The following is a description of a gene set: Mouse Gene Set: MIR_342_3P studied in species Mus musculus from publication Chen Y, Wang X (PMID 31504780) Genes predicted to be targets of miRBase v22 microRNA mmu_miR_342_3p in miRDB v6.0 with MirTarget v4 prediction scores > 80 (high confidence targets)., and this is the list of marker genes: Cep97, Far1, Tctn1, Clec1b, Kdm6b, Knop1, Gucy2c, Zfy1, Nip7, Arhgef4, Akirin1, Ms4a4d, Slc39a13, Zbtb26, Rad51d, Rpgr, Ddo, Ostn, Susd1, Ddx3x, Hivep1, Wdr77, Trpc6, Jazf1, Adam28, Tro, Tfdp2, Vax2, Eif4e, Pramel29, Socs6, B3gnt6, Kdsr, Chst15, Cisd2 (NCBI Gene Id 99732), Prelp, Stk4, Plxna4, Itfg2, Fut8, Cacna1c, Selenot, Snap25, Klhl15, Armcx3, Plk2, Casp2, Mmab, Col1a2, Hycc2, Tcf12, Jade1, Nkap, Tulp3, Elavl2, Fgf10 (NCBI Gene Id 14165), Id4, Wdr37, Tmem35a, Ctbp2, Etaa1, Tlk1, Vsig8, Rsrc1 (arginine/serine-rich coiled-coil 1), Sdcbp, Arrdc3, Kmt5a, Snapc1, Zfp704 (NCBI Gene Id 269407), Harbi1, Tmx1 (thioredoxin-related transmembrane protein 1), Hspbap1, Adgrg2, Rictor, Prpf38b, Fhip2b (FHF complex subunit HOOK interacting protein 2B), Slc6a4, En1, Sh3rf1, Bmp15, Tasor, Arid1b, Emp1, Nrcam, Mrfap1, Ep300, Ate1, Mri1, Emcn, Slitrk2, Zkscan1, Ccdc34, Sh2b1, Dao, Cers3, Dcaf12l1, Ptprc, Zeb1, Dpy19l1, Slc6a8, Ntrk2, Ube2d2a, Ankrd49, Limd1 (NCBI Gene Id 52216), Lasp1, Cyp7a1, Epc1, Ino80d, Fam53c, Sorcs3, Zfp287, Apbb2, Usp37, Sox6 (SRY (sex determining region Y)-box 6), Nsd1, Tgif1, Kcnj6, Eea1, Adarb1, Eda, Rfx3, Wasl, Ubn1, Tanc2, Col25a1, Hook3